The following is a description of a gene set: studied in species Homo sapiens Human Gene Set: HP_ABNORMAL_PROXIMAL_PHALANX_MORPHOLOGY_OF_THE_HAND Abnormal proximal phalanx morphology of the hand, and this is the list of marker genes: FLNB, COL2A1, CDKL5, FGFR3, KIF22, XRCC2, RAB23, LMBR1, CHSY1, TRIO, BHLHA9, IHH, TBX5, FANCD2, ROR2, SHH, MTOR, VAC14, TRPS1, EP300, KIF15, BMPR1B, COL10A1, GNAS, NOG, FIG4, NPR3, GDF5, CREBBP